The following is a description of a gene set: Human Gene Set: GSE3982_EOSINOPHIL_VS_MAST_CELL_UP studied in species Homo sapiens In the present study we used Affymetrix oligonucleotide microarrays to produce gene transcription profiles for the major leukocyte types in humans. This comprehensive dataset enabled us to not only establish which genes were expressed in each leukocyte type, but also which genes were expressed in each subset after activation. The used of a comprehensive dataset of gene profiles from all the major human leukocyte subsets enabled a novel and powerful means for identification of genes associated with single leukocyte subsets, or different immune paradigms. from publication Jeffrey KL, Brummer T, Rolph MS, Liu SM, Callejas NA, Grumont RJ, Gillieron C, Mackay F, Grey S, Camps M, Rommel C, Gerondakis SD, Mackay CR (PMID 16474395) Genes up-regulated in comparison of eosinophils versus mast cells., and this is the list of marker genes: CAMKK2, CCNT2, TNFRSF11B, OR7E87P, PELI1, KRT33A, ZNF281, MROH9, RSAD2, DDX6, SVIL, RERGL, FOLH1B, MUC5AC, CACNA1F, GPR39 (G protein-coupled receptor 39), IQSEC2, OBP2A, TUB, ZNF200, ROS1, TCAP, DDX28, CAMK1D, CYTH1, UBE2B, TAX1BP1, ANGPT1, SMPD3, SDHAF1, FMNL1, APLP1, ENTPD1, ETV6, ITFG2, PITPNM3, RB1CC1, DGCR5, TNFRSF1A, ITGAL, LSM14B, TAF1D, PTEN, DUS2, MYT1, CASP8, SYNE2, DMC1, RTF1, NOTCH2NLA, GTF2B, TTC9, TRPC6, RFPL1, HK3, USP19, ERCC6, MTHFR, ZNF75D, KLF5, MID1IP1, CSF2RB, DOK4, JAK2, GPR65, TMEM143, TAOK1 (TAO kinase 1), PIM2, RIN3, LPGAT1, PHOX2A, ZNF264, NTSR1, ZNF292, GRIA2, DBT, RNF208, NUP50, PCDHGA8, CCDC82, NNAT, FICD, SLA, GSN, CNN2, UBL5, GAL3ST4, SEC62, CD1E, IL10RA (interleukin 10 receptor subunit alpha), MKRN1, TBX1, TMEM131L, APBB2, ATP2B2, GLRB, UCP1, LGI2, EZH1, BLTP1, USP15, RRAD, ITGAX, TSPAN9, SAMSN1, C1orf115, MX2, RXRA, NADK, CYSLTR2, DOK2, C9orf78, TNFSF14 (TNF superfamily member 14), MAP2K7, LSP1, MTMR1, NID1, HMOX2, OMG, PDK3 (pyruvate dehydrogenase kinase 3), SAMD9, SPATA6, TAF5, EPN2, OASL, LILRB2, P2RY13, CTDSP2, SCD5, LIMK2, LMOD1, MTF1, PCTP, RNF24, LRRFIP1, FPR1, TRAPPC2, OR12D2, TPPP, ZNF721, NOTCH2, TP73, CNTRL, LRRC37A4P, MMP25, GIT2, A4GNT, XAB2, CADPS2, MRFAP1L1, MSLN, S1PR1, CHRD, SCUBE3, CBX2, SF3B1, ELF4 (NCBI Gene Id 2000), SNIP1, PLAAT1, ZNF586, ABCA7, PARP8, TCF25, IL6R, MOCS3, STAG2, CHIA, FBXO42, RPL41, MMP15, CSPG4, MTM1, CACNA1S, ACACB, CKB, NLRX1, TSGA10, BANP, SKP2, MARCHF1, TM2D3, APOBR, MMP3, SLC4A10, CDKN2D, ZNF385D, RDH11, DUSP8 (NCBI Gene Id 1850), GNAZ, SATB1, PARP16, KDM5C, HLA-F, CXCR3, SLC27A3, GZMK, COL14A1, MS4A5, ZNF217